Given this list of marker genes TUBB4A, DAAM1, GCHFR, PIP5K1B, PMM1, PEX2, DNA2, DLGAP5, MAST3, RFC3, GUCY1B1, ZFP36, CTSW, CDC25C, KMO, MCL1, CD180, CCNE1 (cyclin E1), RHOH, FANCI, PHEX, TRIM26, FANCA, GAS7 (growth arrest specific 7), RRM2, CAMK4, TADA3, STS, VNN2, ASL, ABHD3, SPP1, APOBEC3B, ROR1, MMD, HCK, EMP3, NEK2, ATP2A3, ERI2, TNFRSF17, PLG, PRIM2, RAPGEF5, RALY (RALY heterogeneous nuclear ribonucleoprotein), CDKN2D, JAG1, RDH16, CD72, TJP1, COCH, BBS4, KIF14, CHEK2, PRIM1, CAMSAP1, SERPINB8, MRTFA, ADAM23, POLD1, KIF20B, GARRE1, RHOBTB1, FST, PLAGL1, SLC17A4, MFGE8, AP3B1, CPM, AOX1, GPR18, RGS4, PTPN18, DPY19L2P2, PHTF2, BLM, ANP32E, SLC15A2, ANXA2P1, MTMR1, TTN, POM121L9P, GRK6, BRCA1, TTK, BARD1, CEMIP, ESPL1, GLA, SPRED2, TRIM9, IRAG2, NUP210, TACC1, STIL, LAMA5, CCDC69, TMSB15A, RRM1, GSDME, RAD51AP1, PLCL2, HMGB3, SPAG5, CDKN2C, GRN, SPIB, PDLIM1, SLC30A3, KPNA6, CSTF2, RPL39L, CDC7, SYNE2, MAPK1, POLA1, POU1F1, GNAZ, PTPN21, NT5E, WASF1, PDIA5, IRS1, C14orf132, SLC25A4, ACAA2, TMPO, TRIB2, CCNF, SLC27A2, CDC25B, ADARB1, BUB1, TES (testin LIM domain protein), EIF4A3, SIT1, ASXL1, TAF5, MTCL1 (NCBI Gene Id 23255), PTPN6, TBC1D1, DLG3, MELK, RASGRP1, BTK, ADAM19, NCAPD3, CDC45, PKIA, MC5R, UVRAG, CDK2, GPM6A, ARHGAP19, NADK, MGLL, DZIP3, ZCCHC24, RGS2, SHMT1, LYN, BCL7A, RARRES2, SPA17, ARHGEF9, CRIP1, DTX4, NUP160, GRK4, AGL, HDAC9, CD19, CD38, BUB1B, CCNA1, TRAT1, CTSA, IRF4, FCHSD2 (NCBI Gene Id 9873), OIP5, DDB2, APOBEC3G, MSH3, NRGN, ITGB3BP, CTSO, CCNE2, MARCKS, NKX2-8, FOXM1, C1orf216, IAPP, REXO5, ARHGAP11A, EPHX2, SYNE1, DPY19L1, PLK4, APBB2, here is a description of the gene set: Human Gene Set: GSE39556_UNTREATED_VS_3H_POLYIC_INJ_MOUSE_NK_CELL_UP species: Homo sapiens The injection of the pathogen-associated molecular pattern Polyinosinic-polycytidylic acid (poly(I:C)) leads to the activation of various immune cells, including dendritic cells (DCs) and Natural Killer (NK) cells. This activation is due to different innate cytokines produced early after injection, in particular IFN-I. The objective of the study was to compare the pattern of expression of IFN-I stimulated genes between DC and NK cells. The project focused on a specific subset of conventional DC, CD8a DC, which responsiveness to IFN-I determines the capacity to activate CD8 T cells by cross-presentation of exogenous antigens. To identify the responses to IFN-I selectively induced in CD8a+ DC, we compared their gene expression profile to that of NK cells, using gene chips, before and after poly(I:C) stimulation. from publication Baranek T, Manh TP, Alexandre Y, Maqbool MA, Cabeza JZ, Tomasello E, Crozat K, Bessou G, Zucchini N, Robbins SH, Vivier E, Kalinke U, Ferrier P, Dalod M (PMID 23084923) Genes up-regulated in NK cells: untreated versus poly(IC).